Given this list of marker genes Hsp90aa1, Trib2, Wdr48, Foxf2, Cdc20, Rnf180, Nxn, Psen1, Ube2n, Fbxo2, Spopl, Marchf7, Birc2, Gbp4, Ticam1, Cry1, Fbxo4, Stub1, Ripk2, Akt1, Prickle1, Ube3a, Kdm1a, Laptm5, Mta1 (NCBI Gene Id 116870), Siah2, Trim44, Ppia, Axin1, Phf23, Arrdc4, Dysf, Rps2, Fancm, Rnf111 (ring finger 111), Skp1, Peli1, Ndfip1, Tgfbr1, Bex3, Hdac3, Sirt7, Rps3, Rps7, Hamp, Psmd10, Ube2l3, Mycbp2, U2af2, Nmi, Tspyl5 (NCBI Gene Id 239364), Mtbp, Ube2s, Dnajb2, Dtx3l, Tbc1d7, Ctnnb1, Rnf40, Ogt, Peli3, Abl1, Birc3, Park7, Mapk15, Cdk5, Topors, Inava, Ube2v1, Cdk5rap3, Ufl1, Tcf25, Fanci, Tm9sf5, Bcl10, Birc7, Usp4, D1Pas1, Rbx1, Mapk8, Ube2srt, Mapk9, Ubb, Rassf5, Hspa5, Sqstm1, Arrdc3, Bmi1, Atg7, Trib1, Rbx1-ps, Xiap, Cblb, Per2, Psen2, Dcun1d1, Sash1, Ube2d1, Btrc, Svbp, Fbxo5, Usp44, Pinx1, Ttc36, Gabarap, Wnk1, Limk1, Sh3rf2, Isg15, Chp1, Ngf, Pten, Fam107a, Gtpbp4, Mad2l1, Rchy1, Trib3, Klhl40, Epm2a, Npm1 (NCBI Gene Id 18148), Fzr1, Rassf1, Lrrk2, Nlrc3, Ndfip2, Cd300ld3, Paxip1, Tspo, Cul3, Nod2 (nucleotide-binding oligomerization domain containing 2), Prkce, Hdac8, Gclc, Wbp1l, Bex2, Spsb4, Ubqln1, Dnaja1, Fbxw7, Cdkn2a (NCBI Gene Id 18560), Washc1, Ivns1abp, Spry2, Plk1, N4bp1, Ubxn2a, Minar1, Sprtn, Nsmce3, Aimp2, Tnfaip3, Bag2, Cep78, Pttg1ip, Caml, Sphk1, Mastl, Hspa1b, Prmt3, Gsk3b, Mtor, Rasd2, Mad2l2, Rpl23, Vps28, Septin4, Amer1, Ddx3x, Nhlrc1, Daxx (NCBI Gene Id 13163), Cdc14b, Ube2v2, Dnaja3, Angpt1, Senp2, Cav1, Ptpn22, Hamp2, Prkn, Sox4, Parp10, Hspbp1, Pef1, Atg5, Ubxn1, Fbxo33, Plaa, Huwe1, Nscme3l, Adgrb1, Hsp90ab1, Chfr, Pdcd6, Tes3-ps (testis derived transcript 3, pseudogene), Arrb2, Pink1 (NCBI Gene Id 68943), Pabpn1l, Bag5, Rpl5 (NCBI Gene Id 19983), Gsk3a, Fgfr3, Gps2, Skp2, Wfs1, Prkcg, Smad7, Bex4, Fyn, Rpl11, Commd1, Derl1, Birc5, Bex1, Cep63 (NCBI Gene Id 28135), Gnl3l, Herpud1, Arrb1, here is a description of the gene set: Mouse Gene Set: GOBP_REGULATION_OF_PROTEIN_UBIQUITINATION studied in species Mus musculus Any process that modulates the frequency, rate or extent of the addition of ubiquitin groups to a protein.